Given this list of marker genes Rnf31 (NCBI Gene Id 85306), Hecw1, Rnf144a, Trip12, Rnf146, Rnf220, Ppil2, Pcgf3, Rnf41, Mkrn3, Nt5c2, Rnf170, Neurl3, Pex10, Fbxo40, Rnf167, Trim6, Med10, Siah2, Trim30a, Rmnd5a, Rnf6, Marchf6, Ppp1r11, Trim30b, Trim12a, Cop1, Ccnb1ip1, Herc2, Sh3rf3, Tmem129 (NCBI Gene Id 69753), Nccrp1, Dzip3, Smurf1, Prpf19, Sh3rf1, Rabgef1 (RAB guanine nucleotide exchange factor (GEF) 1), Rlim, Fbxo17, Rbx1-ps, Trim14, Trim37, Ube4b, Wwp1, Rnf114 (NCBI Gene Id 99401), Trim12c, Trim7, Zmiz2, Fancf, Rnf112, Trim56, Trim71, Rnf44, Triml2, Birc2, Trim11, Rnf11, Trim40, Pja2, Vps18, Med23, Rad18, Rfwd3, Trim13, Trim65, Zzef1, Rnf168, Med11, Ube3b, Sh3rf2, Rnf225, Ubox5, Rnf111, Rchy1, Triml1, Ube3a, Trim69, Trim27, Siah3, Pias2, Btrc, Rnf208, Rnf135, Dtx3l, Bfar, Cbll1, Trim25, Zmiz1, Fbxo15, Med21, Rnf38, Rnf115, Rfpl4, Hltf, Rnf139, Trim32, Ubr4, Trim43a, Ubr5, Marchf1, Rnf2, Mex3c, Maea (macrophage erythroblast attacher), Rnf26, Rnf14, Ark2c, Birc3, Ube2d1, Kcmf1, Prkn, Rnf19a (ring finger protein 19A), Dtx4, Znrf2, Neurl1a, Pex2, Fbxo44, Rbx1, Rffl, Rnf212b, Rnf144b, Cdc42, Rnf166, Asb4, Ufl1, Cbx4, Arih2, Cul1, Rnf113a2, Nhlrc3, Traf6, Zfp598, Nsmce2, Trim75, Znrf3, Rag1, Wdr24, Mylip, Trim72, Cblc, Asb12, Trim34b, Xiap, Med20, Dtx1, Rnf122, Ranbp2, Siah1a, Fbxo2, Rnft2, Bspry, Med31, Ltn1 (NCBI Gene Id 98040), Arih1, Traf5, Pias1 (protein inhibitor of activated STAT 1), Ube3c, Rnf215, Rnf128, Trim60, Syvn1, Rnf123, Med6, Trim45, Zfp451 (NCBI Gene Id 98403), Ubr1, Hdac6, Med1 (mediator complex subunit 1), Wwp2, Mib2, Rnf8, Dcst1, Mib1, Rnf186, Traf7, Marchf8, Nedd4, Med30, Nfx1, Ubr3, Trim9, Trim61, Trim28, Cbl, Rnf7l, Rnf217, Pml, Rnf213, Pias3, Uhrf2, Trim30d, Jade2, Ark2n, Fbxw8, Pcgf5, Ccnc, Trim31, Ubr2, Rc3h2, Mdm2, Hectd2, Rnf13, Vps11, Znrf1, Brap, Trim30c, Msl2, Trim23, Rnf126, Lrsam1, Mkrn1, Rnf216, Atg3, Lonrf2, Marchf7, Trim47, Zswim2, Med17, Med18, Ube4a, Trim44, Marchf5, Huwe1, Trim15, Trim38, Rnf180, Asb2, Rbbp6, Mycbp2, Trim3, Birc7, Atg5, Herc6, Rnf157, Rnf43, Trim34a, Irf2bpl, Trim63 (tripartite motif-containing 63), Smurf2, Traf2, Fancl, Hectd1, Rnf130, Gid4, Trim33, Trim26, Traip, Dtx2, Shprh (NCBI Gene Id 70331), Arel1, Amfr, Ube2k, Mkrn2, Rnf125, Rnf152, Nhlrc1, Wsb1, Trim8, Cblb, Peli3, Rnf20, Rnf40, Trim41, Rnf113a1 (NCBI Gene Id 69942), Rnf10, Rnf121, Nedd4l, Rnf133, Fbxo4, Rnf227, Ube3d, Rnf26rt, Trim17, Birc5, Rnf138, Herc4, Pja1, Med27, Fbxo6, Mefv, Trim52, Rnf223, Ubr7, Topors, Anapc11, Pias4, Ube2d2a, Mul1, Rnf39, Mgrn1, Rnf138rt1, Trim55, Rnf149, Rnf5, Rnf181, Traf3, Trim10, Znrf4, Trim21, Trim62, Hecw2, Uhrf1, Egr2, Trim54, Med24, Trim43b, Rnf34, Cul3, Trim5, Peli1, Peli2, Rnf4, Herc3, Trim43c, Irf2bp1, Nosip, Dtx3, Ankib1, Rnf19b, G2e3, Nsmce1, Rnft1, Neurl2, Trim58, Fbxw11, D7Ertd443e, Med12, Rnf185, Toporsl, Pdzrn3, Trim35 (tripartite motif-containing 35), Rnf183, Chfr, Rnf150, Fbxl22, Trim39 (tripartite motif-containing 39), Cul4a, Stub1, Neurl1b, Atg12, Trim68, Siah1b, Traf3ip2, Hace1 (NCBI Gene Id 73291), Rnf25, Rnf7, Fbxo27, Trim2, Neurl4, Asb1, Trim59, Med7, Fbxo30, Ring1, Rmnd5b, Marchf2, Itch, Rnf145, Cdk8, Rc3h1, Rpgr, Rnf148, Trim50, Trim24, Ube2o, here is a description of the gene set: studied in species Mus musculus Mouse Gene Set: GOMF_UBIQUITIN_LIKE_PROTEIN_LIGASE_ACTIVITY Catalysis of the transfer of a ubiquitin-like protein (ULP) to a substrate protein via the reaction X-ULP + S = X + S-ULP, where X is either an E2 or E3 enzyme, the X-ULP linkage is a thioester bond, and the S-ULP linkage is an isopeptide bond between the C-terminal glycine of ULP and the epsilon-amino group of lysine residues in the substrate.